Given this list of marker genes Gata1 (NCBI Gene Id 14460), Vegfa, Kdm1a, Zfpm1, Ldb1, Smarca4, Hscb (HscB iron-sulfur cluster co-chaperone), Gata2, here is a description of the gene set: studied in species Mus musculus Mouse Gene Set: GOBP_PRIMITIVE_ERYTHROCYTE_DIFFERENTIATION Erythrocyte differentiation which occurs as part of the process of primitive hemopoiesis.